Given this list of marker genes H1-7, AKAP3, TEX15, TSGA10, CYLC2, PGK2 (NCBI Gene Id 5232), LEMD1, ASB17, here is a description of the gene set: Human Gene Set: WEBER_METHYLATED_LCP_IN_SPERM_DN species: Homo sapiens from publication Weber M, Hellmann I, Stadler MB, Ramos L, Pääbo S, Rebhan M, Schübeler D (PMID 17334365) Unmethylated germline-specific genes with low-CpG-density promoters (LCP) in sperm. To gain insight into the function of DNA methylation at cis-regulatory regions and its impact on gene expression, we measured methylation, RNA polymerase occupancy and histone modifications at 16,000 promoters in primary human somatic and germline cells. We find CpG-poor promoters hypermethylated in somatic cells, which does not preclude their activity. This methylation is present in male gametes and results in evolutionary loss of CpG dinucleotides, as measured by divergence between humans and primates. In contrast, strong CpG island promoters are mostly unmethylated, even when inactive. Weak CpG island promoters are distinct, as they are preferential targets for de novo methylation in somatic cells. Notably, most germline-specific genes are methylated in somatic cells, suggesting additional functional selection. These results show that promoter sequence and gene function are major predictors of promoter methylation states. Moreover, we observe that inactive unmethylated CpG island promoters show elevated levels of dimethylation of Lys4 of histone H3, suggesting that this chromatin mark may protect DNA from methylation.